Given this list of marker genes WNT4, PRPS2, AHNAK, PCF11 (NCBI Gene Id 51585), CYRIA, MBD5, NDUFAF3, VPS53, GPC4, NFKBID, BEND6, RELL2, TNFSF15, HOXC4, RNF182, STIP1, FOXN3, ATXN7L1, WNT8B, TGIF1, FOXO4, CACNA1C, NFATC4, NNAT, CKMT1B, LINS1 (lines homolog 1), E2F4 (E2F transcription factor 4), MYH11, RBM14, PATL1, CPNE1, NXPH1, TMEM88, NLK, PSD, CDH5, SP6, PRDM13, HMGA2, ATOH7, C12orf50, CNTN1, STAG2, TNFRSF21 (NCBI Gene Id 51323), LTBP1, ANK3, ERC1, SLC35A2, TTLL6, SP7, CCN2, ASCL2, KLF12, BMF, SMYD2, CALU, TMCO6, ALKBH6, ETV1, HDAC4, CACNG3, PIAS1, ADCY6, NDP, COLEC11, HOXC11 (homeobox C11), FGF13, SLCO3A1, AP1G2, GDI1, ELMO3, FBRS, SPEG, DLX1, DOCK4, CERT1, JPT2, CXCR3, HAUS3, LRMDA, CPSF7, PPP1R12A, ASB4, AGPAT4 (NCBI Gene Id 56895), HCN4, PAK3, ETS1, NSMCE3, NR1H3, IGF1R, CRYAB, POLR3B, PRMT3, AKT2, GBA2 (NCBI Gene Id 57704), EPHA2, CHST8, ACVR2B, OVOL1, SHCBP1L, ARHGAP44, BCKDK, TYRO3, SGMS2, MAP2K6, BLNK, IGFBP6, ZNF485, FGF17, PPFIA2 (PTPRF interacting protein alpha 2), VARS2, ZEB1 (zinc finger E-box binding homeobox 1), PTCH1, CD86, PARP2, SHC3, CLASRP, KAT14, DENND1B, RNF122, GNB2, GUCY1A2, SLITRK1, SERPINB7, POU3F3, PMP22, PARP8 (NCBI Gene Id 79668), ELK4, RDH10, PTPN12, BDNF, BMPR2, TBX19 (T-box transcription factor 19), RBMS2, MN1, ITM2B, EPHB2, ASB7, SLC5A3, SORBS3, MXRA8, HES1, FOLR1, LUZP1, P2RX1, MSX1, TTN, SGCD, ACE2, TACC2, KRT3 (NCBI Gene Id 3850), KBTBD8, DALRD3, ST7L, HOXC6, JARID2, PCK1, ACTB, HCST, BOC, MYH1, ELF5, VAMP3, NFIA, GRAMD1C, SLC26A7, USP2, HS6ST3, PDGFC, GPM6A, P2RY4, PRDM1, TFAP2A, TNFSF18, HOXB2, TES, CAPZA1, IGSF22, FAM50A, DDX17, OSR2, RUNX1T1, ZFPM2 (NCBI Gene Id 56958), PRICKLE3, FPGS, MYOCD, RORA, RFX4, PRKAG1 (NCBI Gene Id 5571), RNF213, SEMA3F, VEGFA, NAA15, CYP26A1, ABCG5, NRGN, GRK5, KCTD4, ODF1, TRIM50, PTGR3, NRP2, RBMS1, LRRFIP1, VIP, ASPA, BCL3, KPNB1, CGN, AGBL5, PLPP3, HOXB4, COL12A1 (NCBI Gene Id 1304), TOR1AIP2, SNCAIP, TMEM95, HOXB5, IRF2BPL, CDK6, SPEF1, TMEM94, TLE3, CA14, SUPT16H, LRP1, ATP6V0D1, HSPB2, RELB, GRIN2B, EHF, HOXA3, PAK6, BCL11A, AMMECR1, NCOA2 (NCBI Gene Id 10499), LRP2, PKIA, KCNQ4, FNBP1L, ANKRD39, AXIN2, LINC01565, CXCL14, HIVEP1, CCDC91, HOXC5, MAGED1, TEAD2 (NCBI Gene Id 95515), RALGPS2, SLC26A10P, NAPB, SAT1 (spermidine/spermine N1-acetyltransferase 1), RASA2, VSNL1, FOSL2, GLP2R, EXOC3L1, UBE2E4P, PHACTR3, CDKN1B (cyclin dependent kinase inhibitor 1B), PDLIM5, BCL2, ARAP3, SYTL2, DCSTAMP, ACTN1, SLC26A6, CXXC4, HDAC3, FAM20B, FGF20, NFKBIE, TBXT, here is a description of the gene set: Genes having at least one occurrence of the motif NNNTGGGAWNNC in the regions spanning 4 kb centered on their transcription starting sites. This matches the transcription factor binding site V$IK2_01 (v7.4 TRANSFAC). species: Homo sapiens Human Gene Set: IK2_01